Given this list of marker genes HMGB1P1, DPEP2NB, SLC22A6, NLRP10 (NLR family pyrin domain containing 10), SNRPG, TRAPPC14, ZNF268, EOLA2-DT, AGAP11, TNKS2-DT, DOLK, PREB, TMEM175, VPS72, LINC00663, GZF1, TCAF2P1, XGY1, ENSG00000257283, LINC01783, KBTBD8, ZNF48, NPIPB3, TUSC1, CHST4, ZNF433, XAGE3, PPP1R3F, CCDC192, TOR2A, IMPA1P1, GTF2H2, PSG7, AIFM2, NPIPB5, RPS13P2, MFSD12-AS1, LLPH-DT, NPRL2, PDE6A, CLDN10-AS1, NFE4, RPL7P24, C10orf55, CEMP1, ENSG00000226180, FAR2P4, FAM200A, AKIP1, FBXO33, TJAP1, MRPS31P2, METTL25B, RPL12P21, NSUN3 (NOP2/Sun RNA methyltransferase 3), EIPR1, LINC01535, RSPH6A, CGB3, GARIN1A, LINC01581, LINC01920, LINC00578, PDCD6, RNU1-134P, CNKSR1, ALG2, DDX10P1, RNU6-118P, ARHGEF3-AS1, ZNF280C, ZNF432, WAPL, GTF2H2C (GTF2H2 family member C), SNIP1, CDC25A, POU6F2-AS2, ZBTB14, RNFT1, TBC1D3P1-DHX40P1, RNU6-272P, PLCE1-AS1, SLC39A9, CPEB1-AS1, ENSG00000253515, SLC47A2 (NCBI Gene Id 146802), SLC25A32, LINC00964, SIAH1, KCMF1, LINC00339, RN7SL741P, PCDHGB7, ANKRD26P1, COPS8-DT, HYAL6P, EPIC1, GLUD2, RSF1-IT1, TM4SF19, SPIN3, RPL12P20, XKRX, POTEF (POTE ankyrin domain family member F), RAD17P2, LINC02616, ELP1, RPL21P57, GBA1LP, CLCN2, TRIM62, UPF3AP3, DNAJC17, PYY2, TNIP2, AKAP17A (A-kinase anchoring protein 17A), CARD6, ODAPH, RNU2-63P, CCNDBP1, ENSG00000247131, ALG10, RN7SL246P, ZSCAN10, LINC02551 (NCBI Gene Id 399978), CPZ (NCBI Gene Id 8532), NDOR1, ALKBH1 (alkB homolog 1, histone H2A dioxygenase), TOMM20L-DT, TRAPPC3, TFAP2A-AS1, TRPC5OS (NCBI Gene Id 100506619), RGPD2, LINC02540, ENSG00000254718, GTF2IP20, RNU6-1039P, RNU6-810P, RNU6-188P, ENSG00000250954, CA5AP1, LINC01610, ZNF317, LINC00689, CIMIP7, DPH7, ZNF354A, CTDP1, MRPL48, COQ7, TTC39C-AS1, MKRN2OS, RPL5P4, RPL21P5, SARS2, CYB5R2, GALE, ZNF725P, CADM2-AS2, TOM1, DNAJC8, RPL13AP5, ADNP-AS1, here is a description of the gene set: The gene expression program underlying the specification of human cell types is of fundamental interest. The study authors generated human cell atlases of gene expression and chromatin accessibility in fetal tissues. For gene expression, the study authors applied three-level combinatorial indexing to >110 samples representing 15 organs, ultimately profiling ~4 million single cells. The study authors leveraged the literature and other atlases to identify and annotate hundreds of cell types and subtypes, both within and across tissues. Our analyses focused on organ-specific specializations of broadly distributed cell types (such as blood, endothelial, and epithelial), sites of fetal erythropoiesis (which notably included the adrenal gland), and integration with mouse developmental atlases (such as conserved specification of blood cells). These data represent a rich resource for the exploration of in vivo human gene expression in diverse tissues and cell types. Human Gene Set: DESCARTES_MAIN_FETAL_CSH1_CSH2_POSITIVE_CELLS studied in species Homo sapiens from publication Cao J, O'Day DR, Pliner HA, Kingsley PD, Deng M, Daza RM, Zager MA, Aldinger KA, Blecher-Gonen R, Zhang F, Spielmann M, Palis J, Doherty D, Steemers FJ, Glass IA, Trapnell C, Shendure J (PMID 33184181) Marker genes curated from the annotated cluster as represented in the Descartes Human Gene Expression During Development database.